Given this list of marker genes Eif2ak3, Eif2a, Scap, Arhgef10l, Spring1, Erlin2, Amfr, Zbtb7b, Srebf1, Srebf2, Paqr3, Insig2, Tmed2, Erlin1, Insig1, Npc1l1, here is a description of the gene set: Mouse Gene Set: GOBP_CELLULAR_RESPONSE_TO_STEROL_DEPLETION Any process that results in a change in state or activity of a cell (in terms of movement, secretion, enzyme production, gene expression, etc.) as a result of a stimulus indicating deprivation of sterols. Sterols are a group of steroids characterized by the presence of one or more hydroxyl groups and a hydrocarbon side-chain in the molecule. species: Mus musculus